The following is a description of a gene set: Human Gene Set: MIR4643 studied in species Homo sapiens Genes predicted to be targets of miRBase v22 microRNA hsa-miR-4643 in miRDB v6.0 with MirTarget v4 prediction scores > 80 (high confidence targets). from publication Chen Y, Wang X (PMID 31504780), and this is the list of marker genes: TSHR, HSP90B1, BAZ1A (NCBI Gene Id 25985), ZNF827, TMEM30A, ARHGAP24, GABRB2, DHX36, UBE2Q1, ATP1B4, ARF6, ALPK2, CDYL2, PKD2, ADAM22, SESN3, UTY, CCDC62, MARCHF6, SESTD1, HYCC2, RPRD1B, PARP15, MAD2L1, TAB2, RAPGEF4, ZNF326, CPSF6, RFTN1, DRD1, DCUN1D4, PSMF1, ZNF367, KIAA0319, DNAH12 (dynein axonemal heavy chain 12), KLHL24, TUBB2A, WDR45B, JAKMIP1, GPR137C, PCSK5, TMEM39A, GOPC, MGAT4A (alpha-1,3-mannosyl-glycoprotein 4-beta-N-acetylglucosaminyltransferase A), CNR1 (NCBI Gene Id 91814), CA8, ZNF780A, GTF3C2, GRIA2, NR2C2, LRP8, MCM6, PNRC1, CPNE4, CFAP47, SYNJ1, PCMTD2, CENPN, HMX2, PTPN4, PLAC1, CPEB2, SPRED1, CENPI, EVI5, HIPK3, NETO1, C1orf21, SNX13, IFNA17, EPHA5, NR1D2, HEXIM1, NABP1, MLLT3, YWHAQ, SEPTIN8, TRAPPC13, PRKCE, CNOT2, CBX1, KLK10, WIF1, MEF2C (NCBI Gene Id 4208), NAT8L, C19orf12, RAB6B, DLX5, COLEC12, PENK, PPP4R3A (protein phosphatase 4 regulatory subunit 3A), RBFOX2, PACSIN2, FBXO11, LDB3 (NCBI Gene Id 1219), LSAMP, SLC35E3, MEIG1, SPN (NCBI Gene Id 6693), AZIN1, ZSWIM6, BBX, YTHDC2, CDH2, LACTB2, FMNL2, N4BP2L1, PLCXD1, RAB9A, GABRA1, IFNA16, KLHL23 (NCBI Gene Id 151230), BMPER, FMN1, DENND5B, DYNLL2, CEP85L, MATR3, CLEC4A, NAP1L5, DEK (NCBI Gene Id 7913), DIPK1C, KALRN, REV3L, KDM7A, BHLHE22, TNRC6C, GINS1, HNRNPA1, TUT4, BLCAP, COG5, U2SURP, PHF13, PNMA2, TP63, NXPH2, TEAD1, DZANK1, PDLIM5, TTC33, RALGAPA1, CTXN3, DRD5, CLMN, GIPC2, TMEM65, LYPD6, THBS1, RIMKLB, HDGFL3, SP4, B3GALNT2, EIF2AK4, HMBOX1, FRY, RICTOR (RPTOR independent companion of MTOR complex 2), RAP1B, OPA3, ARID1B, HERC3, SKP1 (S-phase kinase associated protein 1), PTK2B, C9orf72, PSME3, CTNNB1, INO80D, RRN3, BAZ2B, GIGYF2, BCL11B, PDGFRL, GPR22, TRIM4, SLC6A19, CYP3A7 (NCBI Gene Id 1551), RS1, LGI1, TNRC6B, TRIO, SON, ATP11A, NOL11, BAG4, PHIP (pleckstrin homology domain interacting protein), DOCK4, KHDRBS1, KHDRBS2, NPAS3, SBNO1 (strawberry notch homolog 1), SNX19, THBS2, GPR180, VAPB, ERC2, TNPO1, B4GALT5, LGALS3, ELMOD2, SOCS6 (NCBI Gene Id 9306, suppressor of cytokine signaling 6), PLAG1, SERP1, STON1 (stonin 1), CLECL1P, PI15, BMP8A (NCBI Gene Id 79787), RAB31, SASS6, UBE2D3 (NCBI Gene Id 7323), ANGPT1, SEH1L, TGFB2, GPD1L, PAIP1, PLCB4